Given this list of marker genes LCAT, ABCA1, TREM2, SCARB1, HSPD1, here is a description of the gene set: studied in species Homo sapiens Binding to apolipoprotein A-I. Human Gene Set: GOMF_APOLIPOPROTEIN_A_I_BINDING